The following is a description of a gene set: Mouse Gene Set: GOBP_METHYLGLYOXAL_CATABOLIC_PROCESS_TO_D_LACTATE_VIA_S_LACTOYL_GLUTATHIONE The chemical reactions and pathways resulting in the breakdown of methylglyoxal, CH3-CO-CHO, into D-lactate via the intermediate S-lactoyl-glutathione. Glutathione is used in the first step of the pathway and then regenerated in the second step. species: Mus musculus, and this is the list of marker genes: Glo1, Haghl, Gatd1, Hagh, Pnkd